Given this list of marker genes MT3, LEPR, LRP2, CCNA2, BBS4, STAT3, LEP, INHBB, MKKS, NR1D1, BBS2, FGF23, FGB, CCND1, NR4A3 (NCBI Gene Id 8013), SIRT1, ADIPOR1, GCK, PID1, EDN1, UGCG, here is a description of the gene set: Human Gene Set: GOBP_RESPONSE_TO_LEPTIN species: Homo sapiens Any process that results in a change in state or activity of a cell or an organism (in terms of movement, secretion, enzyme production, gene expression, etc.) as a result of a leptin stimulus. Leptin is a hormone manufactured primarily in the adipocytes of white adipose tissue, and the level of circulating leptin is directly proportional to the total amount of fat in the body. It plays a key role in regulating energy intake and energy expenditure, including appetite and metabolism].